Given this list of marker genes Gm12505, mt-Tl2 (NCBI Gene Id 17736, mitochondrially encoded tRNA leucine 2), Fam111a (family with sequence similarity 111, member A), Zfp999, Rpl15-ps3, Mypop, Gm23793, Mup-ps26, Rex2, Ascc1, Vamp3, Mff, Gm2182, Rbm12, Gm27230, mt-Nd4, Gm13135, Cpne1, Gm8357, Mkrn3, Gm5884, Pomt1, Cfap206, Pnpt1, Duxf1, 3110070M22Rik, Or5m9b, Gm14332, Pank4, Gm15784, Gm18299, Extl1, Gm23043, Vmn2r129, Gm17887, Selenoi, Gm6483, Zfp958, Suco, Atxn1l, Pik3c3, Nat8f2, Btbd35f24, Gm15260, Lemd1, mt-Nd4l, Zfp990, Oaz2, Csta2, Duxf3, Nexn, Gm13163 (NCBI Gene Id 666546), Gm11399, Gm13161 (predicted gene 13161), mt-Ts2, Plekhg4, Gm13148, Gm15564, Upf1, Kalrn, Cog6, Gm20939, Josd1, Btbd35f23, Gm13610, Bst1, Atp5pb-ps, Gm18800, Gm13170, mt-Tp, Trmt10c, Nipsnap2, mt-Tl1, 1810014B01Rik, Timm8a2 (NCBI Gene Id 223262), Gm6726, Tmem267, mt-Tg, Aen, Mrpl32 (mitochondrial ribosomal protein L32), Dnajc1, Anapc16, Gm3786, Cdk10, Htt, Ccn2, Med4, Gm43391, Ttll4, Gm8869, Gm24826, Gm14400, 5330411J11Rik, mt-Th, Gm5924, Gm13238, Drosha, mt-Nd1, Mvd, mt-Tr, AI506816, Gm7461, Gm15270, Gm15446, Inpp5d, Gm7504, Svil, mt-Tv, Gm14333, Gm5301, Ndufa8, Inpp5f, Gm13162, Pds5b, Mir6236, Dld, mt-Rnr2, Cct8, A330035P11Rik (RIKEN cDNA A330035P11 gene), Morn5, Coil, Fyco1, Psma2, Gm8032, mt-Nd5, Abcg2, mt-Nd3, Mettl22, Pramel6, Gm5870, Gm3453, Gm13228, 6820431F20Rik, Chmp2b, Tm9sf2, here is a description of the gene set: Genes containing one or more binding sites for (Naa10) in their promoter regions (TSS -1000,+100 bp) as identified by GTRD version 20.06 ChIP-seq harmonization. species: Mus musculus Mouse Gene Set: NAA10_TARGET_GENES from publication Yevshin I, Sharipov R, Kolmykov S, Kondrakhin Y, Kolpakov F (PMID 30445619)